Given this list of marker genes MATCAP2, TET2, DCUN1D4, CAMSAP2, CHSY1 (NCBI Gene Id 22856), AMMECR1L, PCDHA8, EIF3J, PCDHA1, SGMS2, TFEC, PCDHA9, FEM1B, EML5, JAZF1, ZBTB10, IQCJ-SCHIP1, SERPINH1, SLC5A8, ERCC6, CPEB3, USP37, NFIA, B3GNT5, VEGFA, ZNF704, REPS2, MCL1, MYBL2, SIDT1, NKAPD1, STMN2, WDFY1, RNF19A (NCBI Gene Id 81036), ARHGEF10, ROBO1, JMY, SGCZ, MFAP3, ABHD18, PCSK5, PCDHAC2, ZBTB20, KIF26A, C1QTNF6, ISG20L2 (interferon stimulated exonuclease gene 20 like 2), C10orf55, NFAT5, TIMM8B, NPAS3, PRRC2C, LYSMD1, CCSAP, SS18L1, TFAP2C, MYCN, CEMIP, C5orf15, IFFO1, EFNA5, PRR14L, NSD1, XKR6, PURG, YTHDF3, ABCE1, NAV1, LIN7A, NASP, CEP68, FSTL1, BCCIP, XKR7, ZNF346, OTULIN (OTU deubiquitinase with linear linkage specificity), MINAR1, ARVCF, ULBP2, PPP1R15B, FREM2, SMTNL2, COL25A1 (collagen type XXV alpha 1 chain), AMER1, ING3, GNG12, ADAMTS17, IL1RAP, BMF, MORF4L2, NLRX1, ZFP91 (ZFP91 zinc finger protein, atypical E3 ubiquitin ligase), SPPL2B, BACH2, COL27A1, RFX7, LSM11 (LSM11, U7 small nuclear RNA associated), CLEC2L (NCBI Gene Id 154790), ADAMTS7, COL2A1, AKAP13, COL1A2, ZFX, CAMK4, IGF1, PAIP2 (poly(A) binding protein interacting protein 2), DNMT3B, INA, ZNF282, SCML2, COL22A1, SHROOM2, TRIM63, REST (NCBI Gene Id 5978), SAMD4A, EML6, CRYBG1, ZDHHC21, OSTC, GIT2, PAN2, MARCHF1, PGAP2, DGKD, NAP1L3, SP1, HAPLN3, RAP1GDS1, MUC22, SENP1, SH3BP5L, TPK1, GPX7, NKTR, DGKH, ANKRD13C, AKAP5, TUBB2A, PIK3R1 (phosphoinositide-3-kinase regulatory subunit 1), PINX1, PXYLP1, PCDHA2, HPGD, SLC44A5, COL9A1, RIC1, PARG, ZBTB5, GPR37, RAP1A, ENPP2, OSBPL11, SERINC5, KDM5B, MAPRE2, HS3ST3B1, ANKRD13B (ankyrin repeat domain 13B), ELF2, RERE, DICER1, JARID2, COL11A1, XKR4, SETDB2, KCTD20, TRAF3, ZMIZ1, PCDHA12, FAM13B, KNOP1, NUP160, TDG, DYNLT1, IFI30, ZFP36L1, MXD1, MTMR4, FBN1, CEP97, C11orf54, PDIK1L, MAP4K4, NCKAP5, FAM168B, BTG2, PTBP3, CRISPLD1, DDX3X, RNF39, PMP22, DLG2, MBTD1, CDK6, ATP2B4, TFEB, PI15, MORF4L1, HAS3, SNX24, RAPGEFL1, LASP1, CNR1, ADAMTS9, ZNF469, COL5A1, STX17, LAMC1, SMS, SGK1, USP6NL, RMND5A, SLC16A14, AKT3, BLMH, TNFAIP3, PTEN, DCX (doublecortin), KMT5C, KLHL28 (kelch like family member 28), HIF3A, PGAP1, STRN4, ELN, TMTC3, TAF5, POGLUT2, CDC42BPA, GAB1, CPS1, STMP1, GXYLT2, NREP, REDIC1, LYPLA1, ELOVL4, DOT1L, CCNT2, OTUD4, ING2, FAM241A, DNMT3A, PRR3, RBAK, PCDHA11, HAPSTR1, TMEM236, DTX4, SIRT1, TET1, PPIC, COL4A6, MEX3B, TMEM169, TRAF4, YBX3, PRKG1, CAV2, LAMA2, RARB, COL19A1, FERMT2, COL15A1, DVL3, NKIRAS2, SHPRH, TMEM65, CDC42, TMEM178B, RLF, KCTD5, MOB1A, AKAIN1, TTC9, STX16, SH3PXD2A, SSC4D, CSRNP2, BAK1, KIAA1549, MIDEAS, ICOS, TAF11, CREB5, CBX6, VPS37C, LOX, ANTXR2, N4BP2L1, RND3, ATAD2B, ADAMTS10, DPYSL5 (dihydropyrimidinase like 5), KLF4, ZHX3, DCAF7, GABRP, MGA, GRIA3, TMEM183A, ERLIN2, CCNYL1, RGS1, BRWD3, CPSF7, MED12L, SMIM17 (small integral membrane protein 17), ZNF28, PTPRK, WWTR1 (NCBI Gene Id 25937), PPP1R13B, GNB4, ADAMTS6, EIF4E2, PCDHA10, DIO2, SETDB1, ENHO, ZBTB34, AKT2, RAB30, SPARC, C2orf68, REV3L, CUEDC1, FOXJ2, TCF4, ADAMTS2, HBEGF, DAAM1, DENND6A, ETV6, CLDN1, ASXL3, PXDN, NEXMIF, NKRF, HMCN1, EML4, FGD4, NAV3, PCGF3, KIF26B, SLC6A14 (NCBI Gene Id 282807), DAAM2, SIDT2 (SID1 transmembrane family member 2), BCORL1, IREB2, FBXW7, MAPK10, TRIB2, PCDHA5, SH3GLB1, LOXL4, COL6A3, DOLPP1, LPL, ATRN, REL, TET3, PCDHA3, PCDHA13, COL4A4, UBFD1, ERP44, PCDHA7 (NCBI Gene Id 56141), HRK, CLOCK, ARPP19, CCSER2, SMPD3, GRIP1, PCDHA4, NOTCH2 (NCBI Gene Id 55574), FER, COL5A2, ASAP2, HBP1, LIF, PLP1, COL7A1, HORMAD1, USP34, COL1A1, TLCD3B, PIAS2, TNRC18, PALM, PCDHA6 (protocadherin alpha 6), FRAT2, TNFRSF1A, POLR3E, ATP1B4 (NCBI Gene Id 23439), GID8, EPC1, SLC7A6, SLC30A3, MAP6, CSGALNACT2, PRPF40A, PAPOLG, ZMYM2, COL5A3, MLXIP, NAV2, FRAS1 (Fraser extracellular matrix complex subunit 1), TLL1, COL4A1, ZNF512B, GPATCH2, PCDHAC1, DTWD2, PRKAB2 (protein kinase AMP-activated non-catalytic subunit beta 2), FAM167A, SESTD1, PPM1E, COL3A1 (collagen type III alpha 1 chain), COL4A2, HDAC4, LOXL2, FBXW9, MAPKBP1, RTL6, COL4A5, RHOBTB1, SAMTOR, MAPRE1, AK4, CD276, METAP2, KIF24, RNF138, VASH1, TMOD3, CCNJ, EOMES, here is a description of the gene set: Human Gene Set: MIR29B_3P_MIR29C_3P species: Homo sapiens from publication Chen Y, Wang X (PMID 31504780) Genes predicted to be targets of miRBase v22 microRNA hsa-miR-29b-3p, hsa-miR-29c-3p in miRDB v6.0 with MirTarget v4 prediction scores > 80 (high confidence targets).